Given this list of marker genes Ext2, Sec11c, Pigs, Faf1, Pomt1, Arxes1, H2-D1, Traf2 (NCBI Gene Id 98924), Sec11a, Ugt3a1, Pdia6, Syvn1, Pyurf, P4hb, Sel1l (NCBI Gene Id 20338), Magt1, Pigt, Ubxn1, Pigk, Emc2 (ER membrane protein complex subunit 2), Krtcap2, Map3k5, Hspa5, Ufd1, Emc7, Srebf2, Hyou1 (hypoxia up-regulated 1), P4ha2, Ppib, H2-Q4, H2-Q6, Tap1, H2-Q7, Pdia4, Ern1, H2-K1, Amfr (NCBI Gene Id 23802, autocrine motility factor receptor), Derl1, Srprb, Srpra, Sec61a2 (SEC61 translocon subunit alpha 2), Rpn2, H2-Q2, Ganab, Pigp, Arl6ip1, Ostc, Ern2, Sdf2l1 (NCBI Gene Id 64136), Sec63, Spcs3, Nploc4, Alg14, Calr, Selenos, Ubxn7, Stt3a, Dnajc10, Mzb1, Dpm2, Zw10 (NCBI Gene Id 76189), Emc8, Prkcsh, Emc9, Hsp90b1, Nbas, Tapbpl, Ugt1a1, Spcs1, Emc3, Get3, Sec61b, Ugt3a2, Tmem258, Mmgt2, Rpn1, B2m, Insig1, Elovl6, Afg2b (NCBI Gene Id 613261), H2-Q1, Vcp, Ssr4, H2-Q10, Spcs2, Sec61g, Rp9, Emc6, Dad1, Trex1, Fam8a1, Pigu, Tap2 (transporter 2, ATP-binding cassette, sub-family B (MDR/TAP)), H13, Ryr1, Tapbp, Alg13, Pigyl, Caml, Tusc3, Get1, Rnf125, Fkbp1a, Mmgt1, Sec61a1, Pigm, Mlec, Pigh, Gpaa1, Pigq, Faf2, Ddost, Emc10, Pigc, Rnf139, Stt3b, Arxes2, Insig2, Emc4, Dnajb11, Hsd17b12, Pdia3, Piga (phosphatidylinositol glycan anchor biosynthesis, class A), Emc1, Ost4, P4ha1, Rint1, here is a description of the gene set: studied in species Mus musculus A protein complex that is part of an endoplasmic reticulum. Mouse Gene Set: GOCC_ENDOPLASMIC_RETICULUM_PROTEIN_CONTAINING_COMPLEX